Given this list of marker genes Ier3, Pdia4, Fcer1g, Tmem176a, Itgb1, Lyn, Sub1, Rnh1, Fkbp2, Atp8a1, Lilrb4a, Creld2, Rbx1, Ikzf1, Naaa, Gpr137b, Stip1, Cyth4, Psma7, Tle3, Pfdn6, Serpinb1a, Hnrnph2, Tmem256, Tmem14c, Psmb7, Dynll1, Zfp366, Cst7, Slc39a7, Gpr35, Timm10b, Slamf9, Myd88, Stat3, Gadd45g, H2az1, Ffar2, Prex1, Gatm, Ccr5, Eif4g1, Tmed9, Chchd1, Krtcap2, Ifitm1, Snap23, Spi1, Cdh1, Rrbp1, Ms4a6d, Sdc4, Cux1 (NCBI Gene Id 384239), Napsa, Hsp90aa1, Tmem106a, Sra1, Atp6v0a1, Hip1, Scimp, Ndufb4, Spint1, Hnrnpa3, Srsf2, Cdkn2d, Tank, Mrpl20 (NCBI Gene Id 73950, mitochondrial ribosomal protein L20), Zfp106, Spcs2, Ccl12, Prdx1, Eif5b, Socs3, Ptpn1, Pfn1 (profilin 1), Galnt6, Pdia6, Arf1, Med30, Prxl2b, Mrpl52, Fcgrt, Pdia3, Tmem208, Slfn2, Sbno2, Calr, Dnajb11, Tspo, Bex6, Tspan13, Ddr1, Gpr146, Ssr2, Uqcrb, Basp1, Sdf2l1, Xbp1, Dad1, Bin2, Ppp1r14a, Sf3b6, Gcnt2, Flot1, Srsf9, Psmb9, Rcl1, Ifitm2, Grb2, Id2, Myo1e (myosin IE), Hsp90b1, Il4ra, Csf2rb, Elob, Atp5mc1, Pirb, Fh1, Clec4n, Sdc3, Pmvk (NCBI Gene Id 99841), Pgs1, Txnrd1, Tpm3, Psmc5, Cdk2ap2, Tspan4, Efhd2, Tarm1, Olfm1, Ranbp1, Lrrk1, Mdh2, Smdt1, Idi1, Oat, Macroh2a1, Hspa5, Il21r, Manf, Bcl2l11, Srsf7 (NCBI Gene Id 60426), Bcl3, Yif1a, Ncl, Isca2, Rab3il1, Nme1, Wfdc17, Srsf3, Ssbp4, Arl8b, Ebna1bp2, Ldha, Mrpl15, Cct8, Hspa8, Tmem176b, Rab18, Cyrib, Rab24, Psmb2, Casp6, Fxyd5, Cd53, Cyp7b1, Fgr, Etv3, Gda, Eps8, Srgn, Ctsz, Nemf, Ptges3, Tgfbi, Magoh, Selenos, Fyn, Psma3, Atp6v1g1, Fabp5, Jak2, here is a description of the gene set: Mouse Gene Set: CUI_CDC2_IL10_RESPONSE_UP Cytokines mediate cell-cell communication in the immune system and represent important therapeutic targets. A myriad of studies have highlighted their central role in immune function, yet we lack a global view of the cellular responses of each immune cell type to each cytokine. To address this gap, the authors created the Immune Dictionary, a compendium of single-cell transcriptomic profiles of more than 17 immune cell types in response to each of 86 cytokines (>1,400 cytokine-cell type combinations) in mouse lymph nodes in vivo. A cytokine-centric view of the dictionary revealed that most cytokines induce highly cell-type-specific responses. For example, the inflammatory cytokine interleukin-1β induces distinct gene programmes in almost every cell type. A cell-type-centric view of the dictionary identified more than 66 cytokine-driven cellular polarization states across immune cell types, including previously uncharacterized states such as an interleukin-18-induced polyfunctional natural killer cell state. studied in species Mus musculus from publication Cui A, Huang T, Li S, Ma A, Pérez JL, Sander C, Keskin DB, Wu CJ, Fraenkel E, Hacohen N (PMID 38057668) Genes positively differentially expressed in cell type: cDC2 (conventional dendritic cell type 2) upon treatment with cytokine: IL-10 in mouse lymph nodes in vivo.